Given this list of marker genes MINPP1, INPPL1, SYNJ1, INPP1, INPP5J, INPP5B, INPP5D, INPP5K, OCRL, INPP5E, INPP5A, INPP4A, INPP4B, SYNJ2, here is a description of the gene set: Human Gene Set: GOMF_INOSITOL_TRISPHOSPHATE_PHOSPHATASE_ACTIVITY studied in species Homo sapiens Catalysis of the reaction: myo-inositol trisphosphate + H2O = myo-inositol bisphosphate + phosphate.